Given this list of marker genes SP7, CAVIN2, MAML3, CNTFR, UBE2N, ZBED2, FLI1, SLC5A3, RTN4RL1, JARID2, OVOL1, GNAZ, LUC7L3, TAF5, TAX1BP3, CACNA1C, JMJD1C, ARHGAP26, EFTUD2, ACVR2A, LMO3, FIP1L1, OLFM4 (olfactomedin 4), HNRNPA0, YARS1, RRAGA, HRK, EMC7, GPM6A, BHLHE22 (basic helix-loop-helix family member e22), LMNA, TWIST1, CCDC103, MBNL1, WWC2-AS2, SLC26A6, DKK2, SLITRK2, TMTC2, CMTM4, WDPCP, EMC6, SRPK2, PGBD4, UBALD2, METAP1D, SERTAD4, BEND4, MYO18A, TCF4, CHD6, XKRX, SLC6A5, RORB, PDGFRA, POU2AF1, RHOBTB3, USP9X, H2AZ1, NFYB, GLRA1, LIX1, ITGB3BP, MAP2K5, SERPINI1, C1orf21, HMGA1, HSD17B10, RRM1 (ribonucleotide reductase catalytic subunit M1), FILIP1, SOSTDC1, SLC39A13, LRMDA, NOX4, PDCD10, STOML2, FSTL5, REEP4, SOX4, OTP, ZBTB20, LHFPL1, ERG (ETS transcription factor ERG), PTPN4, DMD, TEAD1, SH2D1A, ETV1, BAZ1A, ARHGAP33, PHOX2B, KIF12, CPA4, SUMO1, CHRDL1, JPH1, KCNN3, NKX2-1, DSCAM, LRRN2, TRERF1, PABIR1, here is a description of the gene set: studied in species Homo sapiens Human Gene Set: PAX6_01 Genes having at least one occurrence of the motif NNNNTTCACGCWTGANTKNNN in the regions spanning 4 kb centered on their transcription starting sites. This matches the PAX6 transcription factor binding site V$PAX6_01 (v7.4 TRANSFAC).